The following is a description of a gene set: species: Homo sapiens Human Gene Set: HP_ABNORMAL_VASCULAR_MORPHOLOGY Abnormal vascular morphology, and this is the list of marker genes: PIGA, ACVR2B, HRAS, LUZP1, KDR, H3-3A, RNASEH2A, JAG1 (jagged canonical Notch ligand 1), ERF, POLR1B, P4HA2, GTF2IRD2, NAA10, SPAG1, ESAM, CEP19, XYLT2, RAI1, CHD4, ARID2, DNASE1L3, FANCE (NCBI Gene Id 2178), FH, SON, NF1, PIK3R2, RSPH9, LIFR, DPYSL5, KLRC4, SLC2A10, PLCB1, PLCB3, SAMD9, CREBBP, GAA, HEY2, ARX, KCNJ8, MECP2, CD81, DNAAF4, UBE2T, FBN2 (fibrillin 2), SLC19A2, CCBE1, ATP6V1A, DLL1, DDX6, KCNJ5, WDR35, HLA-B, F12, EPOR, EPHB4, DOCK6, MRPS16, LOX, YME1L1, MAPT, UBE4B, TSFM, CCNO, ENPP1, RASA1, ACP5, DNAI2, MYOC, ZMYND10, CDH2, CALR, EED, COL1A2, LIPA, FOS, CDC42BPB, LRPPRC, NIPBL, SERPIND1, FADD, AIRE, RRAS2, FRA10AC1 (NCBI Gene Id 57208), TEK, POU3F4, FLT4, RREB1, NR3C1, DGCR2, PAM16, CASP10, LRRC56, RPS10, MYLK, SOX2, MYRF, NCAPG2, PKP2, TUBG1, BRCA2, CHRNG, BRD4, WLS (Wnt ligand secretion mediator), GLI3 (GLI family zinc finger 3, NCBI Gene Id 2737), APOA2, CPS1, VPS35L, ERCC4, PTPN6, CPT2, SMO, PIK3CA, PLOD3, LMBRD1, TSC1, AMER1, STK36, MS4A1, UNC45B, BICRA, CRIPTO, SDHAF2, PAH, SMG9 (SMG9 nonsense mediated mRNA decay factor), F7, SLC25A11, CST3, KCNQ2, TBX1, TBCK, ECE1, PYCR1, FANCL, ADAMTS17, GATA4, TRIP13, IL12RB1, UMPS, TNFSF12, ALG8, RPL31 (ribosomal protein L31), GLMN, GNAI3, SOX4, ESR1, FCGR2C, RIN2, KCNT1, JMJD1C, FBXL4, NONO, MT-ND4L, TGFBR1, QRICH1, NEDD4L, MAT2A, PSEN1, NEU1 (neuraminidase 1), NPC1, UFC1, STX1A, FKBP6 (FKBP prolyl isomerase family member 6 (inactive)), CRELD1, NOD2, HACD1, FGF8, CELSR1, MCIDAS, CSGALNACT1, RSPH3, CNTNAP2, KCNN3, ALPL, H4C9, DARS1, KYNU, NIPA1, ADH5, SIK3 (SIK family kinase 3), CUL7, EXT1, WAS, DYNC2LI1, MKKS, ZMPSTE24, UFD1, RAD21, NIPA2, DRC1, IL12A, HYMAI, SNX14, ROR2, DYRK1B (NCBI Gene Id 9149), MT-CYB, ZNF148, HNRNPK, COL3A1, CDH23 (NCBI Gene Id 7395), MSX2, NAE1, RSPH1, MT-TK, PROC, MPL, GDF2, POLR1D, RPS29, THBS2, GEMIN4, MAX, PTCH1, SCN10A, PTPN22, RAP1B, FANCC, ALX3, SLC12A5, LSM11, DOHH, STAG2, ATP6V1E1, TBL2, ZSWIM6, RBPJ, VAC14, ADAT3, OBSL1 (obscurin like cytoskeletal adaptor 1), SMG8, GNB2, SMAD6, MAP2K1, IFT56, G6PC3 (NCBI Gene Id 92579), RIT1, SHH, PEX19, TMEM237, FUT8, PPFIBP1, CYP7A1, PDE11A, WDPCP, GATA6, ASS1, LARS2, CSF2RB, THPO, NEK9, COMT, PET100, TONSL, DPF2, TERT, GP1BB, RBM8A, RIPPLY2, KMT5B, SPARC, ALG2, RPGRIP1, PRDM13, NPC2, ACSL4, GLA, COL5A2, MT-TQ, EOGT, PALB2, CPLANE1, SEMA3E, CRB2, ALMS1, NSD1, SDHD, TCIRG1, CNTN1, MDH2, SC5D, DNAJB13, STIM1, SPEN, INTU, F2, NKX2-5, MT-ND6, APP, SMARCAL1, CLCN2, MVK, RAB23, ATP6V0A2, GPC6, TMEM260, ATP2B1, FUCA1, OTULIN, SOX11, ANGPT2, SLX4, MPI, CHD7, PTEN (phosphatase and tensin homolog), VPS33A, PDGFRB, VEGFC, CTLA4, PKD1, HSPG2 (NCBI Gene Id 7796), DVL3, UBA1, ALX4, SMARCA2, POLR1C, KMT2A, GATA5 (GATA binding protein 5), DAW1 (dynein assembly factor with WD repeats 1), NF2, IGBP1, GUSB, HBB, ABCD4, TBX4, TREX1, APOA1, MCFD2, RRAS, CDON, ANK1, RET, FLNC, THSD1, BANF1, PPP1R15B, PPP2R1A, GBA1, DMPK, CTC1, FHOD3, RPL15, TRIO, SMAD4, DLL3, PLCB4, CARS1, SPEF2, PKD2, RBP4, RPS15A, LTBP2, ANTXR1, SMC1A, RNASEH2C, GMPPB, SOX18, HLA-DRB1, MAPK1, ALG3, MMP21, MEG3, DCDC2, KIF20A, NKX2-6, TGFBR2, RPL26, BMP2, RPS26, CCM2, SLC20A2, ATP7A, PLIN1, MYH6, BRAF, KRIT1, CFH, PIGO, FTO (NCBI Gene Id 79068), ABCC9, MYH3, CLCN7, TCOF1, EDN1, CCNQ, SLC22A4, TSC2, MLXIPL, GP1BA, CCR1, VHL, EGFR, FBN1, MAPKAPK5, ZMIZ1, MT-ND2, APC2, BRCA1, GATA2 (GATA binding protein 2), WFS1, TBC1D24, CTSA, IL12B, XYLT1, MEGF8, GM2A, STIL, CRKL, SUCLG1, SALL4, SFTPB, TBX20, ANGPTL6, B2M, DIS3L2, TMEM67, MGP, WT1, KANSL1, PUF60, SEC63, TFAP2B, RPL27, COLGALT1, PLAGL1, ATN1, HELLPAR, EXT2, ACTB, FBXO11 (F-box protein 11), SNAP29, SUPT16H, BCR, ADAR, MCTP2, MEFV, CFAP53, IFNGR1, ITGB3, DHPS, GPR35, OTC, SCN2A, ZBTB7A, STRA6, IL6, DNAAF3, MINPP1, SMARCD1, C4A, ALB, TALDO1, RPL9, RPL35A, C1QB, RFT1, PRKAR1A, PAFAH1B1, RNF168, CCDC39, WDR37, HES7, SYK, B3GLCT, FOCAD, GLYCTK, PRKCD, MT-ND5, TULP1, ACVRL1, FANCG, HYDIN, RAC1, ANO1, MED25, GCDH, USP9X, LEMD2, SH2B3, CYP11B1, CCDC47, WAC, DISP1, CCND1, PPARG, LDLR, SOS2, WRN, MARS2, TRAIP, RPGR, TET2, HCCS, F13A1, PCNT, TTR, TWIST1, MRAS, TPM3, RSPO2, DNAH5, CYP11B2, PLOD1, DTNA, CD46, DCX, IL23R, PLCH1, FANCA, TBX5, ZIC3, STX5, DNAAF5, SCN11A, FLI1 (NCBI Gene Id 2313), SMARCB1, BAP1, PCCB, CFAP74, FOXH1, MT-ND1, MCCC1, LMAN1, PBX1, ACAD9 (NCBI Gene Id 96656), DNAH9, GLUL, SDHA (succinate dehydrogenase complex flavoprotein subunit A), B3GALT6, F10, TRIP4, TMCO1, KAT6B, DPAGT1, WDR19, RPS24, RAF1 (Raf-1 proto-oncogene, serine/threonine kinase), IGF2, ERAP1, PPP1CB, MAP1B, MESP2, USP18, MMP2 (NCBI Gene Id 4313), ODAD1, DNAAF1, DDX11, NFIA (NCBI Gene Id 4774), SMARCC2 (NCBI Gene Id 6601), DIAPH1, CFAP221, JAK2, MAD2L2, RPL11 (ribosomal protein L11), PRKG1, AGPAT2, IFT140, BUB1B, POLA1, BUB1, TP53, IDH1, ERCC8, ODAD3, GNA11, LPL, SALL1, SHANK3, ZMYM2, ROBO4, TMEM94, ARL6IP6, PRKCZ, NEK10, SCAF4, NDUFA8, NDUFB11, TAF4, TRIP11, CLCN3, HEXB, DNAAF6, ARHGAP31, CASZ1, PSTPIP1, SMARCE1, MYOCD, ESCO2, PIK3CD, PLXNA1, MKS1, PKD1L1, SMARCA4, PNPLA2, CRTAP, ADAMTS10, ZNF687, MAF, VCP, CYP27A1, NAGS, POLR1A, PEX12, IKBKG, PROS1, MMUT, RPL10, PAK2, HDAC4, EIF2AK4, SNORD118, MASP1, HCK, HIRA, PIGL (phosphatidylinositol glycan anchor biosynthesis class L), PNP, NOTCH3, PMM2, TPP2, SMPD1, DEPDC5, MYCN, MID1, MT-TC, SLC25A22, FANCD2, MED12, SPECC1L, EMILIN1, VPS37D, CMPK2, HOXA1, CXCR4, KDM5A, RFWD3, MST1, FGFR1, TMTC3, OCLN (NCBI Gene Id 4950), AGGF1, SIX3, IPO8, LFNG, FGG, CCDC22, TNFSF11, PTDSS1, BRF1, CLN6, VWF, ODAD4, UBR7, OTUD5, PRDM16, ROBO1 (NCBI Gene Id 6091), FANCI, SKIC2, PGM3, HABP2, CAVIN1, LIPC, SSR4, MT-TW, BAZ1B, SF3B2, LMX1B, XRCC2, MLX, NT5E, DPM1, MT-TL1, RNF213, BUB3, AMMECR1, ERCC3, RPS7, CEP57, PIGT, FIG4, MAP3K7, STAT3, HLA-DPB1, CLIP2, GHR, EFEMP1, CD55, CCDC8, TGFB2, DNAJC30, ANAPC7, IRF2BP2, FGFR2, FGB, SNRPB, FGFR3, PRIM1, MT-TF, EIF4H, RPS17, ATRX, ASXL2, RERE, ARSL, TGFB3, NFKB1, FOXC2, SMC3, TRPV6, WDR26, KMT2B, CYP1B1, GNAQ, TMEM270, DNAAF2, NAA20, GALNT3, GGCX (NCBI Gene Id 2677), PIK3CG, TNNT2, HADHB, DLL4, PIK3R1, LIG3, GALE, ADAMTSL1, COL4A1, CAT, COX7B, NGLY1, PCSK9, CLN8, DOCK8, SELENOI, ZIC2, HPGD, ARID1B, DNAJC5 (DnaJ heat shock protein family (Hsp40) member C5), ZAP70 (NCBI Gene Id 7535), CALM3, NR2F2, COL4A2, AXIN1, MT-CO2, ADK (adenosine kinase), HTRA1, PTPN11 (NCBI Gene Id 84990), NME5, THSD4, NOTCH2, SPRED2, LMNA, PCGF2, PIK3C2A, FOXP2, NLRP3, DLK1, MYD88 (MYD88 innate immune signal transduction adaptor), TREM2, RPL18, SKIC3, SNX10, CTU2, UBR1, STAT4, DHCR7, ARF1, PPP1R17, DNM2, NCF1 (neutrophil cytosolic factor 1), RNF31, HIBCH (NCBI Gene Id 26275), GUCY1A1, PSMD12, PCCA, GJA5, MT-CO3, WNT4, ANKS6, CLCNKB, OFD1, CHMP2B, ALG5, WASHC5, FASLG, CFAP300, TGDS, KAT8, TRAF7, HYOU1, RPL35, CYP26C1, ACTA1, DPH5, IFIH1, DDX3X, SLC12A3, COQ4, LRP5, EPAS1, USP48, GTF2I (general transcription factor IIi), ALDH1A2, CFAP298, ACTA2, PLD1, STT3A, TNNI3 (NCBI Gene Id 7137), DPM3, POLR3F, EFEMP2, APOE, TMEM106B, SCN9A, GAS2L2, HEXA, NDE1, PSAP, RSPH4A, COL18A1, PRKCSH, NOS3, ACTG1 (actin gamma 1), LYN, CD19, AFF4, BMPR2, NFKB2, DNMT3A, COL5A1, FZD4, ALDH18A1, SNRPN, TGFBR3, CAV1, SMC5, ITPR1, CSF2RA, PDCD10, ITGA2B, CFI, KDM3B, THOC6, NAA60, PRDM6, GPC3 (glypican 3), CTCF, SH3PXD2B, FGA, COA6, CACNA1C, GJC2, ERCC6, SLC39A13, POGZ, TAB2, TGIF1, HLA-DPA1, STXBP1, BICC1, ERMARD, MFAP5, MCCC2, MED13L, EBF3 (EBF transcription factor 3), C1S, ARPC1B, COG6, PLXND1, RASA2, GRN, SDHC, ABCG5, ADA2, DGCR8, MYPN, BUD23, TNFRSF13B, HGD, EPHX2, CEP295, PACS1, TNXB, ASAH1, FARSB (NCBI Gene Id 112957), MYBPC3, CCDC40, KAT6A, RNU7-1, NEK1 (NCBI Gene Id 51037), CUX1, DNAL1, PEX1, GABRD, C1R, DLST, CBS, APOB (apolipoprotein B), SDHB, ENG, ADAMTS13, HSD11B2, NEK8, PRPF3, BICD2, DNAJB11, RBM10, ACTC1, ELN, ZMYM3, LCAT, RAB34 (RAB34, member RAS oncogene family), ABCA1, LIMK1, TELO2, SH2D1A, PRKACB, PGM1, MTHFR, BEST1, SRY, GATA1, SUFU, DACT1 (NCBI Gene Id 51339), GPIHBP1, PPT1, FLNA, ADAMTS3, RPL8, LTBP4, MT-CO1, BCL11B, FBLN5, ALX1, PTH1R, FKTN, ARFGEF2, ATP6V1B2, SRCAP, HEATR3, NPHP3, BPTF, MMP14, NODAL, UQCRFS1, ADAMTS19, PRTN3 (NCBI Gene Id 5657), TBX2, PHGDH, MGAT2, GANAB, FOXF1, CD109, TCF4, NDP, SLC34A2, NXN, ABCC6, CTSD, CLXN, BRIP1, BCOR, RAD51C, BGN, ALG9, IVD, CADM3, KNSTRN, GDF1, DDX59, LMOD2, NOTCH1, ZFPM2, NFIX, GLI2, DHCR24, DNAH1, KRAS, PDPN, CHUK, ASCC1, C12orf57, B3GAT3, MT-ND4, LAMB2, SLC29A3, NKAP, CHRM3, XIAP, SLC35A2, BSCL2 (NCBI Gene Id 84753), DGCR6, ZFX, FANCF, CD96, RPS28, CEP120, SOX10, GYS1, USP8, NADSYN1, TNFRSF13C, MMP23B, SAMHD1, AASS, RNASEH2B, SMAD3, ABCG8, IL10, FIBP, ERCC2 (NCBI Gene Id 7269), TPM2, GJA8, MNX1, METTL27, FOXJ1, COL1A1, BMPR1A, ARID1A, SIN3A (NCBI Gene Id 25942), STAT1, EIF2AK3, DNAH11, OSGEP, MMACHC, RPS27, GTF2IRD1, CIITA, RNU4-2, IFT27, CR2, SMOC1, GJA1, CIROP, TP63, MEF2A, CWC27, CDC42, PIEZO1, EHMT1, WBP4, SEC24C, SF3B4, LZTR1, AKT1, SERPINE1, ODAD2, ARVCF, UBE2A, CXCR2, NME8, SIAH1, SLC25A24, GAS1, SKI, RPS19, NPPA, UBAC2, PRKCH, LDLRAP1, MYH7, FN1, FOXE3 (forkhead box E3), CD244, IFT43, ZNF699 (NCBI Gene Id 374879, zinc finger protein 699), SIX6, IL12A-AS1, ITGA2, GALC, EP300, FLNB, FAS, MEIS2, PDGFB, ALG12, AEBP1, FGF10, NFKBIL1, ALOX5AP, UBE3B, ERCC5, KIF1B (NCBI Gene Id 57598), DNAAF11, APOA5 (apolipoprotein A5), LRP6, KDM6A, TTC12, MT-ATP6, ZNF462, STAT2, SMAD2, LTBP1, RAD51, SERPINF2, POLR3A, C2CD3, KMT2D, CDK8, IDS (iduronate 2-sulfatase), AGXT, MED11, F13B, MT-TS2, GLB1, ICOS (inducible T cell costimulator), CHST3 (NCBI Gene Id 9469), DYRK1A, AGO2, TBK1, TKT, SOS1, CELA2A (NCBI Gene Id 63036), ABL1, TAOK1 (TAO kinase 1), NPR3, AMACR, RTL1, SEMA4D, COG4, PIGN, RPL5, TNFRSF1A, EZH2, SPTBN1, KCNE5, GPC4, KCNAB2, HTRA2, ZEB2, FANCM, ESS2, MYH11, YY1, FAT4, TANGO2, KCNH1, PQBP1, ODC1, PRNP, FMR1, PORCN, RFC2, WIPF1, YY1AP1, NSMCE2 (NCBI Gene Id 286053), CFC1, FANCB, BRCC3, CITED2, KIF5A, F5, FOXE1, RPS20, SLC37A4 (NCBI Gene Id 84965), TMEM127, SCN1A, RNU4ATAC, TLL1, CACNA1D, EIF4A2, MT-TV, NAGA, RSPRY1, FKBP14, IGFBP7, GNPAT, TLR4, IFNG, NRAS, FOXC1, DNAI1, CBL, TRRAP, SCN5A, F8, MT-TH, TSR2